Given this list of marker genes TAOK2, NEDD9, DYNLL1, DYNLRB2, C5orf15, SDE2, TRERF1, POLR3H, SCN2A, KCNMA1, SRP72, CCNG2, CIMIP6, EFNB3, NKX2-2 (NK2 homeobox 2), DZANK1, AKAP13, SPATA18, TMEM95, HSPG2, NPR3, DNAL4, PASK, KIF6, CBX6, ITGB8, GMPR2, SCAMP4, STRN4, PRKN, GABRB3, SDCBP2, GET3, GRIK2, RAVER1, GOLGA2P7, IQCD, GABARAPL2, TBC1D16, ATRX (ATRX chromatin remodeler, NCBI Gene Id 6475), MARK3, FKRP, SAXO4, FILIP1, LRP2, LRRC56, TTLL4, CFAP69, TMEM190, MDH1, FOSB, TPGS1, SALL2, POLR3F, ANXA1, IL20, PIK3R4, PRRG2, KMT2D, SPATA7, RHOBTB2, COQ8B, SEC14L1, NEDD8, TPPP3, REEP4, PRDM4, PACRG, IQCA1, HRAS, DIS3L2, TNRC6A, LRRC46, ASB7, DRC3, TPCN1, HSPBP1, TOM1L2, SLC6A8, ALMS1 (ALMS1 centrosome and basal body associated protein), TMEM62, GRIK5, FAM76A, ADAT3, SLITRK1, ATP6V1D, DSCAML1, SLC25A3, CDKL5, DNAJB4, UBB, NRGN, NHSL2, CXorf58, CPD, FKBPL, PDE6C, PYGB (glycogen phosphorylase B), CUX1, RBM14, GRM3, DNAJC1, DNAH7, PDE1A (NCBI Gene Id 5136), PPP1R7, USP30, TBATA, APOO, CDC14A, ACBD3, AP1M1, TMEM53, DCTN1, CEP164, ARL4A, TUSC3, ZFR, LINS1, RGS6 (regulator of G protein signaling 6), FGR, RNF138, ZNF365, JOSD2, CCDC81, UBE2O, PES1, PNKD, RASGEF1A, CACNA1D, HMGCS1, CCDC65, DNAL1, CNTF, NME5, TTC16, EIF2S1, ARMC3, HM13, CPXCR1, MGST3, MRPL10, ODAD4, PTCH1, TSC22D1, MXD4, CDK20, KIF3B, MED25, TBPL1, FAM53B, LINC00649, XRCC1, here is a description of the gene set: Comprehensive identification of all functional elements encoded in the human genome is a fundamental need in biomedical research. Here, we present a comparative analysis of the human, mouse, rat and dog genomes to create a systematic catalogue of common regulatory motifs in promoters and 3' untranslated regions (3' UTRs). The promoter analysis yields 174 candidate motifs, including most previously known transcription-factor binding sites and 105 new motifs. The 3'-UTR analysis yields 106 motifs likely to be involved in post-transcriptional regulation. Nearly one-half are associated with microRNAs (miRNAs), leading to the discovery of many new miRNA genes and their likely target genes. Our results suggest that previous estimates of the number of human miRNA genes were low, and that miRNAs regulate at least 20% of human genes. The overall results provide a systematic view of gene regulation in the human, which will be refined as additional mammalian genomes become available. species: Homo sapiens Human Gene Set: CYTAGCAAY_UNKNOWN Genes having at least one occurrence of the highly conserved motif M34 CYTAGCAAY in the regions spanning 4 kb centered on their transcription starting sites. The motif does not match any known transcription factor binding site. from publication Xie X, Lu J, Kulbokas EJ, Golub TR, Mootha V, Lindblad-Toh K, Lander ES, Kellis M (PMID 15735639)